The following is a description of a gene set: Human Gene Set: GOCC_PLASMA_MEMBRANE_REGION A membrane that is a (regional) part of the plasma membrane. species: Homo sapiens, and this is the list of marker genes: NDUFS7, ADAM11, SLC30A5, SLC46A1, KCNJ10, SLC7A11, CA4, GNAO1, PLXNB1, CHRNB2, SLC5A1, FERMT1, ZMYND10, RAP2A, LRRTM3, ELFN2, LDLRAP1, AMN1, SLC47A2, SLC22A12, GABRA6, CHRNA4, TAS2R46 (NCBI Gene Id 259292), ABHD6, PARD3, CNTFR, CNR1, PFKM, RYK, STIM1, NHERF4, ORAI1, PDPN, C1QC, NOD2, GPI, KCNE4 (NCBI Gene Id 23704), RAB11FIP3, TACSTD2, SSTR3, SLC13A2, CAVIN4, SLC29A1, EPS8L2, EHD2, GPER1, ABCA8, SNAP29, PLEK2, LRP2, CBL, ADAM17, ZNRF2, SLC51B, MUC20, FXYD1, MAGEE1, C2CD2L, PLPP2, MFSD4B, ABCC2, AIF1, SLITRK2, ATP6V1G1, SLCO1A2, CHRNA3, ITSN1, FFAR4, GPR158, CASK, SLCO2B1, ADCYAP1R1, PKD1L1, SEPTIN2, MUC1, SLC6A6, STX19, NHERF2, DHRS3, ABCC11, CHRNA7, ARF6, KCNE1, GNA12, F2R, BBS9, RIMS3, TRPA1, LIN7C, APC, ADCY8, KCNE2, NSG2, WWC1, LRRC4B, IL31RA, GABRR2, ABCG5, PAPPA2, ARC, CDHR5, ADRA1A, CLTRN (NCBI Gene Id 57393), SYDE1, DRAM2, FGD2, NCAM2, DUOX1, CYP4F2, TF, HPN, CNIH3, PSTPIP1, ADCY3, FARP1, GPR143, MYOF, FSCN1, CDH17, KRT8, NAALADL1, WHRN, CAV3, LRFN3, IL6R, TMEM30A, SLC4A2, HDAC6, DLG1, RAB27A, CEACAM5, ARHGEF4, TMEM174, ARPC2 (actin related protein 2/3 complex subunit 2), BMX, GRIN2D, SLC39A3, SKAP1, THEM4 (thioesterase superfamily member 4), MEN1, MAP7, USH2A, FBXO2, KCNJ2, CNTN6, SEMA4B, KCNN4, STX4, TJP1, SLC22A13, TTYH1, PKN2, ADAM22, ITGA9, SLC22A8, CAVIN3, DSG1, PLCG2, BEST2, CDHR1, PALS1, SLC6A2, RAPGEF2, PODXL, CD81, RAC1, JAG1, TNIK, ATP1B3, PDE6B, GLRA3, CPLX3, GABBR1, PSD3, CLSTN2, PTEN, ATP1B1, FXYD5, CDH8, PSD, OTOF, AP2B1, PDE6H, SARM1, SLC23A1, LRFN1, NF2, PHLPP2 (PH domain and leucine rich repeat protein phosphatase 2), UTRN, DENND1A, BSND, DTNBP1, AHCYL1, GABRA5, SLC7A13, HAS2, APH1A, SLC5A6, SCNN1D, NUMB, FGD5, NEDD4, ACP4, SLC6A12, SLC26A4, SHANK3, ITLN1, ANXA13, GPR161, CLDN19, CD34, CHRNA2 (NCBI Gene Id 1135), P2RX6, PSENEN, SLC39A10, CDH2, ENPEP (NCBI Gene Id 2028), SCTR, MSN, FAIM2, RAB17, EFNB2, DMTN, PTPRO, MCHR1 (NCBI Gene Id 2847), CLCN3, WASF2, SCN3A, NLGN4X, SLC22A4, PACSIN2, SLC39A8, FOLR1, PI4K2A, GABRE, SLC38A3, HCN2, ANP32E, SLC7A8, SLC9A3, PCDHB13, KCNJ4, KNCN, CACNG7, TENM2, RAB3GAP2, ATP6V0D2 (NCBI Gene Id 245972), DOCK8, MASTL, OSCP1, CD38, IGSF21, RAB21, SLC5A3, SNAP25, TTC8, KCTD8, CIB1, MPP3, MTCL1 (NCBI Gene Id 23255), ARHGEF18, SYNE1, SPIRE2, MXRA8 (matrix remodeling associated 8), SORCS3, SLC1A5, GRID2 (NCBI Gene Id 2895), ANXA2, OSMR, GRIN2A, SLC22A1, CHRM1, SLC26A5, PKD2, KCNA5, KCNQ5, PICK1, DPP4, CA12, SLCO1C1, RGS7, HTR5A, SLC43A1, PRKAA1, ADGRB3, VASP, ADAM29, PDXP, FXYD2, CLASP2, CLCNKA, NHERF1, NPTN, FXYD4, PDE6G, SLC2A5, GRIA1, SLC4A11, GABRG1 (NCBI Gene Id 2565), SLC4A1, ADAM20, SHISA8, ZC4H2, ALPK2, SLC22A3, TFRC, SLC16A2 (solute carrier family 16 member 2), FLOT2, NAPEPLD, DDN, HTR3C, CLDN7, DMD (NCBI Gene Id 548327), DTNB, SYAP1 (NCBI Gene Id 94056), SLC3A2, FRMPD2, CNKSR2, SYT7 (NCBI Gene Id 9066), EVC2, ZDHHC17, KSR1, PLPP1, SVOP, TNFRSF10A (NCBI Gene Id 8797), SI, CACNG3, EPS8L3, NETO1, GPR151, DOK7, CDHR2, STX3, DNAJC6 (DnaJ heat shock protein family (Hsp40) member C6), OTOG, NETO2, PRRT1, PTPRQ, AMN, WDR73, JAK2, CLDN17, INPPL1, GABRA2, ROM1 (NCBI Gene Id 6094), SMPD2 (NCBI Gene Id 6610), CLSTN3, NRXN2, MAP4K2, SLC15A2, UPK3A (uroplakin 3A), CHRNG, SLC22A9, GABRB1, RAB25, SCNN1G, VANGL2, PLD1, PLPP3, SLC10A2, LRP8, ST14, SLC2A2, MPP2, ATP6V1B2, ACY3, EPPK1, PDE6A, CLCA4, CLMP, SYNDIG1, SPATA13, UPK1A, SLC39A4 (solute carrier family 39 member 4), GLRB, ITGB1, HMCN1 (hemicentin 1), BBS2 (NCBI Gene Id 583), ASIC5, EPB41, MS4A4A, SLC44A4, MAPK1, ADGRL2, UMOD, SLC15A1, CACNA2D2, CD36, OPRK1, SLC20A2, SEMA4F, DCC, SLC14A2, GSG1L, CLCN2, CLRN2, IGSF5, SLC6A20 (NCBI Gene Id 56960), GP2, SLITRK3, PARD6G, ABHD17B, LPAR1, LHFPL4, RIPOR2, CNTNAP4, SLC22A18, MUC17, PDZK1IP1, NAIP, CD300LG, MTMR2, SLC6A19, LRRTM1, SLC17A5, UPK1B, GABRP, SLC12A2, CTNNA2, SLC16A8, GABRG3, SLC5A8, GRM3, ABHD17C, ATP1B2 (NCBI Gene Id 482), SYNE2, MICALL1, UNC13B, AQP10, AIF1L, ATP2B1, CFTR, ABCC5, IFIT5, TRPC4, ABHD17A, PRKG2, CSPG4, PARD6B, HTR3E (NCBI Gene Id 285242), ABCB5, KATNBL1, CEACAM20, C5AR2, SLC4A5, TSPEAR, ABCB1, FGR, C1QTNF5, PLXND1, CHRM3, EPHA4, EPS8, KCNJ8, PDE2A, HIP1R, ERBB2, IDE, DUOX2, SLC36A1, SLC51A, MFSD10, HTR3A, SLC13A1, GJB6, LRRC7, CHRNA5, SLC1A7, BBS1, PDLIM4, NEO1, SLC52A3, SLC7A7, DNAJA3, MTSS2 (MTSS I-BAR domain containing 2), ENPP1, SUSD4, ADGRG2, ABCG2, SLITRK5, NCKAP1, SLCO5A1, PIP5K1C, SORBS1, HEPH, MYO6 (myosin VI), SPEF1, KCTD12, SLC17A1, CRYAB, GRIA2, ITGB4, GNB5, UPK2, SEPTIN12, CNTN1, STXBP1, SHROOM2, NRXN1, SLC12A1, SLC26A9, CEACAM1, ADORA2A, BMPR2, PPP1R9B, SAPCD2, CSPG5, RDH12, SLC31A1, AP2M1, NKD2, SLC2A7, PCDH17, CLDN6, RIGI, AQP8, DSTYK, PCDH10, STX11, ABCC3, CLCNKB, RGS7BP, OCEL1, GABRR3 (NCBI Gene Id 200959), IL1RAPL1 (interleukin 1 receptor accessory protein like 1), SPTBN2, PLK4, CTSB, PALM, ICAM2, RAB35 (RAB35, member RAS oncogene family), SHANK2, NRP1, PSEN1 (presenilin 1), SLC26A3, C2CD5, SLCO4C1, GNAS, STXBP2, SEPTIN6 (NCBI Gene Id 23157), ATP2B4, GRIK2, RGS9, ARL13B, SLC6A13, DSG2, SPRY4 (sprouty RTK signaling antagonist 4), FAM107A, THBD, DNM2, GRIN1 (NCBI Gene Id 2902), PLVAP, FAT1, CADPS2, GNAT1, CD8A, P2RX1, PTGIS, TLN1, FGF22, PRKCG, TBC1D10C, IGSF9, EPCAM, RIMS4, GUCY2D, SLC6A7, CHRNB4, ADGRE2, ZFYVE19, SLC16A1, HTR3D, DAG1, CNTN2, OCLN, GABRA1, VEZT, SCNN1A, SLC39A5, SLC9B2, TMEM231, SLC41A1, CRB3, MREG, PIANP, IGSF8, NECTIN1, RAB27B, KCNC1, MAL2, SLC7A1, SLC1A2, SLC14A1, SYTL1, TSHR, ATP4A, SLC43A2, RAB18, PRR7, DLG4, NRXN3, AQP3, LRRC4, CNGB1, PLA2G4F, F2RL2, KCND2, CAVIN2, SLC5A10 (solute carrier family 5 member 10), INPP5K, GRIK1, CHRM4, KIAA1614, TRPV4, TCTN3, CR1, ABCA1, ATF4, KIFAP3, CNGA2, SLC6A3, SLC6A14, CYS1, LRRC4C, ABCA7, SLC8A3 (solute carrier family 8 member A3), RAB34, KCNB1, APPL2 (NCBI Gene Id 55198), MUSK, SELPLG, KIF17, AKAP5, AJAP1, MEGF11, MAPRE1, NOS3, MTMR6, PEX19, ATG9A, SLC17A4, CD44 (CD44 molecule (IN blood group)), ACTN2, ERC1, LHFPL5, HVCN1, CHRND, GABRB2, INSR, LAMP5, P2RX2, GPM6A, SPRY2, SLC6A11, PRKCZ, LCP2, FN1, BBIP1, CRHR1, AKT2, ANK1, PKHD1, KLHDC8B, KCNH1, MARVELD2, LDLR, GRID1, SLC38A1, GRIK4, ELFN1, SLCO4A1, FZD3, KCNC3, GABRD, AQP7, ROBO2, PAK1, SLC29A4, TRPM8, SLC17A2, SLC1A1, PDZD11, CLDN1 (claudin 1), CDKL5, SCARB1, KCNJ9, RHOA, SLC26A7, STRN, ANXA1, MYO10, P2RY1, NOS1AP, HTR1B, TPM1, ITGAM (NCBI Gene Id 3684), RP2, SCRIB, EPS15, GABRR1, CNIH2, BBS5 (Bardet-Biedl syndrome 5), KCNK1, DDR2, NAPA, SHC4, LIPE, SLC38A4, MLC1, STC1, C5AR1, PRKACA, MET, TMEM17, ANKRD45, PNOC, ATP6V0D1, EZR, SH3YL1, RPH3A, DIAPH1, PRKAR1A, MYH9, CNGA1, SCN5A, ERBB4, KL, CA9 (carbonic anhydrase 9), CNTNAP2, VWC2, NME1, ASIC1, TMEM108, SCN10A, NLGN4Y, SH2D3C, UNC13C, B4GALT1, SLC2A1, COL13A1, C1QA, GJA1, MAL, ANK2, SYDE2, KCNA2, CAV2, EFNB1, LRRC15, SRGAP2, MYH10, NEDD9, ITGA3, KIF20A, EFNA5, IQCE, SLC6A9, LCT, TGFA, CRKL, OPRD1, FLOT1, TAMALIN, SLCO1B3, JCAD, MTMR9, AQP9, KCNC4, GRIA3, IL10RA, CEACAM7, NSG1, PLCG1, SLC47A1, ATP4B, TCTN2, GNA13, EHD3, BMPR1A, ERC2, CTSK, CFL1, FSCN3 (fascin actin-bundling protein 3), GRIN2C, SLC22A2, CLSTN1, RAB11A, AKR1A1, SLC22A6, ATP7A, RNF10, ARF4, OPN4, SIGMAR1, CAV1, RAPSN, ADD2, PTH1R, RHCG, PRCD, ARHGEF2, ASIC2, CLDN3, NEDD4L, PDE4A, CNTN5, ATP6V1B1, SLC13A3, STK39, ATP1A1, SLC4A9, GABRA4, PTPRJ, SLC2A9, SLC4A8, SORCS2, MUC13, SELE, TRPV5, TMEM235, GRIN2B (glutamate ionotropic receptor NMDA type subunit 2B), AP2A1, SLC7A5, AGER, GAD2, SLC8A2, SLC11A2, SHROOM3, SLC22A5, ADAM23, ATAD1, RDX, PPFIA2, AQP4, OTOA, PKD2L1, MOSMO, CNGA4, SLC5A7, EPHA2, ANO1, NDE1 (nudE neurodevelopment protein 1), BAIAP2 (NCBI Gene Id 10458), NTNG1, PKHD1L1, DIAPH3, MIP, SHISA6, SPIRE1, CPO, SIPA1L3, PLEKHO1, LRRTM2, LRFN2, RHOC, SLC34A2, GPR157, SORBS2, MTTP, ADAM30, SLC40A1, PCDH8, RHO, MYO1A, S100G, GABBR2, IQSEC3, OR2A4, PDZK1P1, TGFBR3, BVES, GAP43 (NCBI Gene Id 2596), ATP6V1E1, IGSF9B, SLC5A12, SHROOM1, CEP55, SLC26A1, CHRNB3, PPP1CC, P2RY12, FZD6, SLC9A4, GRID2IP, ANTXR1, MGAM, FLRT3, GLRA1, SLC22A7, CADM3, STK26 (NCBI Gene Id 51765), LRP6, DLC1, GPR88, GRM5, SLCO1B3-SLCO1B7, LCP1, TRPM6, LMO7, TIRAP, NDRG4, CADM1, BBS4, DLL1, AQP5, ERBIN, GRM1, FASLG, NINJ1, ATP1A3, ATP2C2, SLC26A6, ABCG8, CHRNA6, CD177, SHISA9, ADGRV1, CHRNA10, SLC4A10, KCNK2, PLCD3, SLITRK1, SLCO3A1, LEPR, RHBG, TGFBR2, TFPI, SSH1, ABCB11, SLC6A8, EFNB3, CHRNE, CTSL, CRB1 (crumbs cell polarity complex component 1), SH3BGRL3, PLEKHG4B, MACF1, SLC1A3, DGKB, KCNQ4, PDE4D, LRRTM4, LYPD4 (LY6/PLAUR domain containing 4), AQP1, TWF1, ABCC8, PICALM, SYP, PACSIN1, SCNN1B (NCBI Gene Id 6338), PCDH9, SPRED1, ASPM, ZG16B, CYP4F12, CUBN, SNCAIP, DPEP1, CLCA2, ATP2B2, AURKA (aurora kinase A), NRP2, SLCO6A1, CACNG5, SLC7A9, SLC39A6, DRD5 (NCBI Gene Id 7883), ADRB2, ATP8B1, PKN1, ECT2, BBS7, RAPGEF6, STXBP3, CA11, GRIN3B, PSD4, NCSTN, SLC27A1, STAMBP, CNKSR3, LIMA1, SRC, RACGAP1, PIP5K1A, TCIRG1, NOTCH1, IGFBP2, SLC4A7, BEST1 (bestrophin 1), TAS2R4, SLC6A18, EPS8L1, EVC, STX1A, GRIK5, UNC5A, KCTD16, CALHM1, ARHGAP45, ADCY1, FSD1, NRGN, TLR9, PDZK1, PDGFB, ATP2B3, SEMA4D, TMEM67 (transmembrane protein 67), EHD1, NIPSNAP1, CFAP126, TACR3, HPGD (15-hydroxyprostaglandin dehydrogenase), GABRB3, PARD6A, RIMS2, CACNG8, MYO7A, GRIK3, KIF18A, KRT19, PTPRD, GPHN, GNAT2, ATP6V1A, ERBB3, NOD1, APBA1, CDH16, FMR1, ECRG4 (ECRG4 augurin precursor), CLN3, HMCN2, NLGN3, TACR1, PLET1, WDPCP, PTPRS, CA14, SMO, LINGO2 (leucine rich repeat and Ig domain containing 2), SHROOM4, LRP1, PTPRH, GABRG2, SYT1, NLGN1, SLC28A3, IRS1, ADGRL1, SNAP91, HAX1, PSEN2, GASK1A, GRIP1, KCNC2, SLC9A2, CLDN5, HSP90AA1, CDH13, SLC39A14, LRRK2, KCNJ16, ITGA8, TMEM114, CHRNA9, HTR2A, CACNA2D3, ADRA1B, HCK, PIEZO1, NEU3, ADAM21, HHIP, STX2, BSG, IZUMO1R, PTCH1, PLLP, CLDN4, GLRA2 (glycine receptor alpha 2), AQP7B, GPR179, SLC16A7, MAPK3, PSD2, AKAP7, ITGAV, ADORA3, SLC34A3, GABRA3, SLC9A5, PKD1, PLEK, CBLN1, CDH10, SLC34A1, APP, RANGRF, NTNG2, SSPN, ITGB2, ABCC4, UNC13A, SLC22A11, ENO2, CEACAM6, AKAP6, CRB2, MYO1D, CDH15, SLC26A2, CACNG2, EPB41L5, RHOB, TMUB1, BRWD1, ADRA2A, PATJ, ANK3, PRKCI, FBXO45, GABRQ, HPCA, NRG1, SLC3A1, DSP, HLA-G, PROM1, HCN1, SCIMP, MYO1C, SRPX2, KCND1, ENTPD1, SLC10A1, LRP4, RASGRP2, BST2, EFCAB7, ATP1A2, CTNNA1, FRMD6, SLC9A1, SYT11, KCNJ3, CLDND1, MPDZ, S100P, CHRNA1, PROM2, GRIA4, SLC19A1, LIN7B, ARPC1A, EEF1A1, FAP, RIMS1, DBN1, RPS3, IQGAP1, EPHA7, SLC27A4, SYNJ1, PLEKHA1 (NCBI Gene Id 59338), PDE9A, SLC24A4, DLG3, SLC6A4, TMEM240, SLC16A12, AQP2, SLC1A6, PRRT2, SGCE, CAVIN1, PLD2, NLGN2, RAB11FIP4, DCTN3, AKAP9, GRM2, TEX101, EMP2, SLCO1B7, CLIC5, CLTA, ATP7B, CLDN8, SLC16A3, PRKAR2A, TAS2R43, CNR2, CASR, CNNM2, SLCO1B1, GM2A (NCBI Gene Id 2760), SLC29A2, RAB8A (NCBI Gene Id 4218), DLG2, VSIG1, LRFN4, PITPNM1, NECTIN3, CBLIF, APC2, ENPP3, CNNM4, NTRK3, CHRM2, CSMD2, PLPPR4, FERMT2, CD9, SLC12A5, NRCAM, DRD1, CDH1, FLRT2, GRIN3A, TRAPPC4, ACE2, SLC26A11, CTNNB1, SLC12A6, TREM2, CYP4A11, CHRM5 (NCBI Gene Id 1133), NHS, GRIPAP1 (NCBI Gene Id 84538), SPTBN1, ASAH2, CD1D, LPO, SLC27A5, CYBRD1, SLC43A3, FCRL3, EPB41L3, CLTB, STX1B, PDGFRB (NCBI Gene Id 5159), SLC4A4, LRFN5, DRD2, MS4A1, KCNMA1, MKLN1, SLC16A6, ITGB3, SLCO2A1, SLC23A2, OPRL1, PARD3B, ADAM10, CXADR, PALM2AKAP2, HYAL2, SNTG1, CALHM3, SEMA4C, DGKI, TEK, ITSN2, PLEKHG6, SLC16A5, KCNQ1, LPAR2, TESC (tescalcin), SLC2A13 (NCBI Gene Id 114134), DIO1, CHRNB1, ABCC10, CACNA2D1, DST, ITPK1, SLC16A10, CACNA1C, ATP6V0A4, SLC28A2, SHISA7, EPHB2, LIN7A, SLC28A1, KCND3, FXYD6, CYBA, ADORA1, RALA, CORO1C, MTDH, ADTRP, DAGLA, SLC30A1, HTR3B, SLC17A3, ATP6AP2, SLC9A8, EGFR, AJM1, ITGA5, SLC5A11, KCNA1, TXNDC15, ARL13A, KANK1, SLC5A2 (NCBI Gene Id 6524), FRMD1, GPR37L1, CACNG4, SVIL, MYLK, ABCC6, SEPTIN7, NPC1L1, ABCB4, MFRP (NCBI Gene Id 83552), ABCC1, FZD9, PRTN3, ATP12A, MAPT, SLC12A3, SHANK1, NOS1, CRIPTO, GPIHBP1, GRM7, THY1, PLB1, TRPV1, GNAT3, GHSR